Given this list of marker genes WEE2, PANX1, TRIP13, PATL2, TUBB8, CDC20, here is a description of the gene set: species: Homo sapiens Human Gene Set: HP_OOCYTE_MATURATION_ARREST Oocyte maturation arrest (OMA) can manifest as failed in vitro fetilization/intracytoplasmic sperm injection (IVF/ICSI) attempts using affected oocytes. Oocyte maturation arrest